The following is a description of a gene set: Human Gene Set: GOBP_REGULATION_OF_ESTABLISHMENT_OF_PROTEIN_LOCALIZATION_TO_CHROMOSOME studied in species Homo sapiens Any process that modulates the frequency, rate or extent of the directed movement of a protein to a specific location on a chromosome., and this is the list of marker genes: TCP1, SPIDR, ACD, CCT6A, WRAP53, USP7, TERF1